The following is a description of a gene set: Human Gene Set: GOBP_VAGINA_DEVELOPMENT studied in species Homo sapiens The reproductive developmental process whose specific outcome is the progression of the vagina over time, from its formation to the mature structure., and this is the list of marker genes: LHX1, BAK1 (NCBI Gene Id 578), MERTK, ESR1, TYRO3, AXL, LRP2, BAX, RBP4, WNT5A